Given this list of marker genes Gls, Otc (ornithine transcarbamylase), Pycr2, Cln3, Ass1, Lgsn, Slc25a12, Gls2, Asl, Oat, Glul, Aldh18a1, Noxred1, Nags, Pycr1, Pycr3, here is a description of the gene set: The chemical reactions and pathways resulting in the formation of amino acids of the glutamine family, comprising arginine, glutamate, glutamine and proline. Mouse Gene Set: GOBP_GLUTAMINE_FAMILY_AMINO_ACID_BIOSYNTHETIC_PROCESS studied in species Mus musculus